The following is a description of a gene set: Formation of the polybromo-BAF (pBAF) complex Mouse Gene Set: REACTOME_FORMATION_OF_THE_POLYBROMO_BAF_PBAF_COMPLEX studied in species Mus musculus, and this is the list of marker genes: Bcl7c, Actl6a, Smarcd3, Smarcd2, Smarca4, Smarcc2, Bcl7a, Actb, Brd7, Smarcd1, Bcl7b, Smarcc1, Smarce1, Pbrm1, Smarcb1